Given this list of marker genes GNMT, SLC25A13, NNMT, KAT2A, PCK2, USP7, CRTC2, FBP2, GPD2, SLC35B4, MIR103A1, PGAM1, PGP, KAT2B, PPP4R3B, SIRT1, TCF7L2, ALDOC, RANBP2, FOXO1, TPI1, PCK1, G6PC2, PGAM2, GPD1, AKR1B1, ERFE, ZNF692, WDR5, EP300, NLN, ENO3, PPARA, PGM1, ADIPOQ (adiponectin, C1Q and collagen domain containing), OGT, GOT1, CLK2, PC, ARPP19, SLC37A4, GCK, PPARGC1A, MDH2, PDK2, C1QTNF3, DGKQ, NR3C1, PFKFB1, SLC25A10, SIRT7, GCG, SELENOS, MIR107, SORD, G6PC3, LEP, PTPN2 (NCBI Gene Id 5771), PER2, G6PD, GPI, SIRT6, SESN2, PPP4R3A, INS, FBP1, SERPINA12, SLC25A11 (NCBI Gene Id 8402), MST1, PRKAG1, LEPR, ALDOB, DGAT2, PGK1, ENO2, MTCL2, SDHAF3, PRKACA, ATF3, ENO1, PGK2, ATF4, C1QTNF12, CHST15, SIK1, CRY1, NR0B1, G6PC1, ACADM, PGD, RBP4, PRKAG2, DDB1, SLC39A14, SDS, PRKAG3, here is a description of the gene set: Human Gene Set: GOBP_MONOSACCHARIDE_BIOSYNTHETIC_PROCESS species: Homo sapiens The chemical reactions and pathways resulting in the formation of monosaccharides, polyhydric alcohols containing either an aldehyde or a keto group and between three to ten or more carbon atoms.